Given this list of marker genes BARD1, SP100, FERMT1, INSIG1, FAM76B, UBAC2, TXN (thioredoxin), ERLEC1, EI24, RAB23, MDFIC, YOD1, SUMO1, APOD, OS9, DERL3, SVIP, CD36, DERL2, PKIA (cAMP-dependent protein kinase inhibitor alpha), CDK5, ADIPOQ, NFKBIA, RANGAP1, NF1, YWHAB, UBE2G2, PKIG, CHP1, PARK7, HDAC3, CABP1, UBE2J1, UFM1, SIRT6, ANGPT1, SUFU, here is a description of the gene set: Human Gene Set: GOBP_NEGATIVE_REGULATION_OF_INTRACELLULAR_PROTEIN_TRANSPORT Any process that decreases the frequency, rate or extent of the directed movement of proteins within cells. species: Homo sapiens